Given this list of marker genes AK2, CMPK2, CMPK1, MPP1, AK7 (NCBI Gene Id 122481), AK3, AK9, LRGUK, AK8, DLG2, GUK1, DLG1, AK6, TJP2, CARD11, CASK, AK1, AK4, MAGI3, AK5, here is a description of the gene set: Catalysis of the reaction: a ribonucleoside 5'-phosphate + ATP = a ribonucleoside 5'-diphosphate + ADP. Human Gene Set: GOMF_NUCLEOSIDE_MONOPHOSPHATE_KINASE_ACTIVITY studied in species Homo sapiens